Given this list of marker genes LBR, ACVRL1, SMAD4, NAGA (alpha-N-acetylgalactosaminidase), GDF2, ENG, here is a description of the gene set: Human Gene Set: HP_LIP_TELANGIECTASIA species: Homo sapiens Lip telangiectasia Telangiectasia (that is, the presence of small dilated superficial blood vessels) of the lips.